The following is a description of a gene set: studied in species Homo sapiens Human Gene Set: GOCC_CONDENSIN_COMPLEX A multisubunit protein complex that plays a central role in chromosome condensation in meiosis and mitosis., and this is the list of marker genes: NCAPG2, NCAPD2, SMC2, NCAPH, NCAPH2, NCAPG, SMC4, NCAPD3